Given this list of marker genes TLR3, TLR1, LY96, CHUK, CD14, TICAM1, IKBKG, IRAK2, BGN, S100A9, MYD88, TLR6, VCAN, TLR2, TLR4, SFTPA1, HMGB1, RHOA, TIRAP, IRAK1, HSPD1, S100A8, IKBKB, IRAK4, here is a description of the gene set: from publication Schaefer CF, Anthony K, Krupa S, Buchoff J, Day M, Hannay T, Buetow KH (PMID 18832364) Endogenous TLR signaling Human Gene Set: PID_TOLL_ENDOGENOUS_PATHWAY species: Homo sapiens